The following is a description of a gene set: Human Gene Set: GSE3982_EOSINOPHIL_VS_MAC_DN In the present study we used Affymetrix oligonucleotide microarrays to produce gene transcription profiles for the major leukocyte types in humans. This comprehensive dataset enabled us to not only establish which genes were expressed in each leukocyte type, but also which genes were expressed in each subset after activation. The used of a comprehensive dataset of gene profiles from all the major human leukocyte subsets enabled a novel and powerful means for identification of genes associated with single leukocyte subsets, or different immune paradigms. Genes down-regulated in comparison of eosinophils versus macrophages. from publication Jeffrey KL, Brummer T, Rolph MS, Liu SM, Callejas NA, Grumont RJ, Gillieron C, Mackay F, Grey S, Camps M, Rommel C, Gerondakis SD, Mackay CR (PMID 16474395) species: Homo sapiens, and this is the list of marker genes: ALCAM, SRP9, ATP2B4 (NCBI Gene Id 54594), ARID5B, SLC11A2, GGCT, LSM6, RDH11, RNH1, PCCA, VWA8, MID2, BANF1, RANGRF, LUZP1, TMEM53, GLRX5, IL27RA, RASSF4, PLA2G15, BSCL2, MYO6, INVS, ATP2A2, SSBP1, ENG, OTUB2, SMARCC1, RAB11A, DPAGT1, C3, MAPKAP1, CAST, TUBB3, IQCG (IQ motif containing G), CSNK2A2, PERP (NCBI Gene Id 64065), UGDH, EIF2S1, SCD, P4HTM, COLGALT1, ENO1, GPALPP1, PFDN6, LIMA1, KIF23, NF1, DNAI2, FYCO1, GLRX3, DNM1L, SRSF8, MRPL34, MRPL4, PLAU, NSA2, ZW10, HSPE1, PCP4, IARS2, UPF3A, MAB21L1, ABCC3, AIMP1, CCNC, DEGS1, DYRK4, GSTT1, IGFBP1, CASP7, PLEKHO1, DNMT1, TLR7, EPHX1, GSN, PRRC1, LRP3, OPTN, ITGAV, COX4I1, RPS6KB1, ASPM (assembly factor for spindle microtubules), UTP18, CD4, PEX19, PDXK (pyridoxal kinase), ATP13A2, HBEGF, MBD2, TTC23, PIK3C2B, MANF, CETN3, BAD, ADCY3, TBC1D19, NIPSNAP1, WDR3, LEPROT, MTX2, ALDOA, ATP5PF, SKIC3, GALNT12, ATP6V1G1, SP3P, MRTO4, UBE3A, NDUFAB1, TIMM8A, IDH1, GSTK1, VGLL4, ANKRD13C-DT, RASL10A, NDUFB2, LNPEP, MCUR1, DHRS3, RNPEP, CISD1, ACTL6A, SUCLG2, MMP2, TOMM70, SCG5, TACC2, HGH1, CBFB, SEMA3C, TCF12, SERBP1, PGRMC2 (progesterone receptor membrane component 2), INHBA, HARS1, NDUFA9, DPH2 (diphthamide biosynthesis 2), TOMM40, SERPINB8, PDSS2, SLC12A8, MARCKS, PMVK, UMPS, DCTD, SLC6A12, STARD8, MAP3K4, CYBB, CLNS1A, TAF1B, HMMR, BLCAP (NCBI Gene Id 10904), MAP4K3 (mitogen-activated protein kinase kinase kinase kinase 3), BCKDHA, CLIC2, ZNF593, ISOC2, MCM4, TFAM, PCK2, DOCK3, ADGRA3, MACROH2A1, VDAC3, ELOC, CALML4, DMXL1, SEC31B, SASH1, NARS1, CSE1L, VAT1, SLC12A7, UBE2V2, AHCYL1, ATP5F1C, ABI3BP, PHB1, DAP3, CMAS, ABCF2, YIPF1, GATD3, UBA2 (ubiquitin like modifier activating enzyme 2), CISH, RHEB, TIMP2, CCT5, DDRGK1, CAAP1, GRWD1, MILR1, MPZL1, PRRG1, CENPM, CHD9, NKIRAS2